Given this list of marker genes DUSP8, DUSP1 (dual specificity phosphatase 1), DUSP16, STYXL2, DUSP4, DUSP29, DUSP3, DUSP6, DUSP2, DUSP26, DUSP14, DUSP9, DUSP18, DUSP7, DUSP10, DUSP21, DUSP13B, DUSP5, here is a description of the gene set: species: Homo sapiens Human Gene Set: GOMF_MAP_KINASE_PHOSPHATASE_ACTIVITY Catalysis of the reaction: a phosphorylated MAP kinase + H2O = a MAP kinase + phosphate.